The following is a description of a gene set: Top highly correlated genes positively associated with poor survival of patients with suboptimally debulked ovarian tumors. Despite the existence of morphologically indistinguishable disease, patients with advanced ovarian tumors display a broad range of survival end points. We hypothesize that gene expression profiling can identify a prognostic signature accounting for these distinct clinical outcomes. To resolve survival-associated loci, gene expression profiling was completed for an extensive set of 185 (90 optimal/95 suboptimal) primary ovarian tumors using the Affymetrix human U133A microarray. Cox regression analysis identified probe sets associated with survival in optimally and suboptimally debulked tumor sets at a P value of <0.01. Leave-one-out cross-validation was applied to each tumor cohort and confirmed by a permutation test. External validation was conducted by applying the gene signature to a publicly available array database of expression profiles of advanced stage suboptimally debulked tumors. The prognostic signature successfully classified the tumors according to survival for suboptimally (P = 0.0179) but not optimally debulked (P = 0.144) patients. The suboptimal gene signature was validated using the independent set of tumors (odds ratio, 8.75; P = 0.0146). To elucidate signaling events amenable to therapeutic intervention in suboptimally debulked patients, pathway analysis was completed for the top 57 survival-associated probe sets. For suboptimally debulked patients, confirmation of the predictive gene signature supports the existence of a clinically relevant predictor, as well as the possibility of novel therapeutic opportunities. Ultimately, the prognostic classifier defined for suboptimally debulked tumors may aid in the classification and enhancement of patient outcome for this high-risk population. studied in species Homo sapiens from publication Bonome T, Levine DA, Shih J, Randonovich M, Pise-Masison CA, Bogomolniy F, Ozbun L, Brady J, Barrett JC, Boyd J, Birrer MJ (PMID 18593951) Human Gene Set: BONOME_OVARIAN_CANCER_POOR_SURVIVAL_UP, and this is the list of marker genes: RUNX1T1, ARHGAP6, SRSF11, TAX1BP1, IGFBP5, HERC1, SKIC3, GULP1, ZBTB16, KL (NCBI Gene Id 9365), RECK, LIMCH1, LEPR, PDE8A, EFEMP1, EID1, ITM2B, CERK, PEX3, UBL3, REV3L, PSD3, RB1CC1, RAB2A, KCNAB1, FAT4, SIRT1, SEC63, TSPAN7, CCPG1, THSD7A